The following is a description of a gene set: Any process that modulates the frequency, rate or extent of T-helper 17 cell lineage commitment. Mouse Gene Set: GOBP_REGULATION_OF_T_HELPER_17_CELL_LINEAGE_COMMITMENT species: Mus musculus, and this is the list of marker genes: Lgals1, Tbx21, Loxl3, Il23a, Ep300, Cd69, Opa1 (NCBI Gene Id 74143), Tnfsf18, Brd2, Brd4